The following is a description of a gene set: Bowing (abnormal curvature) of the vocal folds. Human Gene Set: HP_BOWING_OF_THE_VOCAL_CORDS Bowing of the vocal cords species: Homo sapiens, and this is the list of marker genes: NOTCH2NLC, LRP12, GIPC1, MATR3, RILPL1